The following is a description of a gene set: from publication Chen Y, Wang X (PMID 31504780) Genes predicted to be targets of miRBase v22 microRNA hsa-miR-10395-5p in miRDB v6.0 with MirTarget v4 prediction scores > 80 (high confidence targets). Human Gene Set: MIR10395_5P species: Homo sapiens, and this is the list of marker genes: SLC10A2, CSPP1, SAR1B, GNA13, ERICH3, GNB5, VWC2, ANTXR1, NT5E, MAN1C1, HARBI1, GSG1L, PAM (NCBI Gene Id 5066), SPA17 (sperm autoantigenic protein 17), IGF2, SPICE1, CEP120, TRDN, TATDN1, IGF2BP2, MRPS24, ERG28, KAT6A, DCLK1, SLC24A2, SMURF1, XRN1, ARHGAP20, FOXQ1, GARIN6, ANKEF1, ZNF860, FAM217A, TNRC6A, PRKRA, MRPL11, PLPP5, PCDH9, MPP3, HECW2, LARS1, INTS6, TMEM236, WASL, LIPI, BECN1, URGCP-MRPS24, WNK2, ZNF280D, SET, GLIPR1L2, VSTM4, USP9X, NFATC3, PDZD8, C12orf56, ZNF813, PPP4R4, ADIPOQ, CRACD, SUCNR1, KALRN, GAPDH, TMTC3, SCYL2, LSAMP, LGALS8, SH3GLB1, MBTPS1, STAG2, MED14OS, RHOT1, IFNA2, SPAM1